The following is a description of a gene set: RHOJ GTPase cycle Mouse Gene Set: REACTOME_RHOJ_GTPASE_CYCLE species: Mus musculus, and this is the list of marker genes: Arhgap32, Arhgap26, Trio, Pik3r1, Arhgap5, Ocrl (OCRL, inositol polyphosphate-5-phosphatase), Prex1, Depdc1b, Dock8, Syde1, Ophn1, Pik3r2, Arhgap21, Arhgap35, Rhoj, Arhgap1